Given this list of marker genes KLK9, KLK1, PRKCA, PDLIM7, NAAA, CLDN9, RAB2A, CDC37, MKNK1, EMC4, ATXN7, PPFIA4, TES, PVR, LHPP (phospholysine phosphohistidine inorganic pyrophosphate phosphatase), CRB3, ZNF706, MPHOSPH6, KRT14, DNM1, NISCH, SEPTIN5, SERPINB1, MED24, BCL2L2, GYS1, AS3MT, TSPAN33, EFHD2, PORCN, VEGFA, SLC25A14, TNNT2, PLAGL2, CNDP2, PIGU, HID1, POLR3K (RNA polymerase III subunit K), ALX3, COPB2, INSRR, TPD52, THSD1, RAMP3, KIF2A, PKP1, TMEM191C, PAXIP1, RAPGEF3, IL15RA, GBE1, USP17L24, TXNDC11, CA9, MT1X, UBXN2A, CSDC2, CLDN3, IL24, ENO2, KRTAP19-1, DNAJB6, EPB41L4B, KDELR3, CASP6, HIGD1A, DLL4, SERPINE1, PKP2, TPM3, ERO1A, GCNT2, PHEX, HOMER1 (NCBI Gene Id 9456), CDR2, SLC66A2, GALK1, REM2, ODF2, SLC25A29, GPR35, NASP, MAN2B2, GP1BB (glycoprotein Ib platelet subunit beta), ABCD4 (NCBI Gene Id 5826), LPIN1, here is a description of the gene set: Impairment of the complex regulatory network of cell death and survival is frequently the reason for therapy resistance of breast cancer cells and a major cause of tumor progression. We established two independent cell lines from a fast growing mouse breast tumor (WAP-SVT/t transgenic animal). Cells from one line (ME-A cells) are sensitive to apoptotic stimuli such as growth factor depletion or treatment with antitumor agents (e.g. doxorubicin). Cells from the second line (ME-C cells), which carry a missense mutation at the p53 codon 242, are very insensitive to apoptotic stimuli. Co-cultivation experiments revealed that the ME-C cells mediate cell death resistance to the ME-A cells. Microarray and Western blot analysis showed that osteopontin (OPN) is selectively overexpressed by the ME-C cells. This glycoprotein is the most abundant protein secreted by the ME-C cells and we obtained strong indications that OPN is the main antiapoptotic factor. However, the OPN containing ME-C cell medium does not alter the expression level of pro- or antiapoptotic genes or known inhibitors of apoptosis (IAPs). Its signaling involves mitogen-activated protein kinase (MAPK)/extracellular signal-regulated kinase (ERK) kinase (MEK)1/2 as the kinase inhibitor PD98059 restores apoptosis but not the Akt inhibitor. In the ME-A cells, mitochondrial cytochrome c release occurs with and without external apoptotic stimuli. OPN containing ME-C cell medium does not prevent the mitochondrial cytochrome c release and caspase-9 processing. In serum starved ME-A cells, the OPN containing ME-C cell medium prevents caspase-3 activation. However, in doxorubicin-treated cells, although apoptosis is blocked, it does not inhibit caspase-3. This indicates that the ME-A cells distinguish between the initial apoptotic stimuli and that the cells possess a further uncharacterized control element acting downstream from caspase-3. Human Gene Set: GRAESSMANN_RESPONSE_TO_MC_AND_SERUM_DEPRIVATION_DN Genes down-regulated in ME-A cells (breast cancer, sensitive to apoptotic stimuli) upon serum deprivation for 22 hr in the presence of medium concentrate (MC) from ME-C cells (breast cancer, resistant to apoptotic stimuli). studied in species Mus musculus from publication Graessmann M, Berg B, Fuchs B, Klein A, Graessmann A (PMID 17160024)